The following is a description of a gene set: studied in species Homo sapiens The chemical reactions and pathways involving nicotinamide adenine dinucleotide phosphate (NADP+), a coenzyme that interconverts with its reduced form, NADPH, in many redox and biosynthetic reactions. Human Gene Set: GOBP_NADP_METABOLIC_PROCESS, and this is the list of marker genes: MTOR, RPE, TALDO1, NUDT13, TIGAR, TP53I3, PC, SHPK, NOX1, RBKS, RPIA, NOCT, TP53, TKT, ALDOB, IDH2, DERA, MLST8, ACACB, PGLS, G6PD, RPTOR, ME2, GCK, PRPS2, NADK2, ME1, RPEL1, NUDT17, PGD, NUDT12, NADK (NCBI Gene Id 65220), NNT, ALDH1L1, DCXR, H6PD, FMO2, ALDH1L2, MDH1, IDH1, ACO1